Given this list of marker genes GNB2, GJA5, DNAJC19, DPH5, SVBP, ATP6V0A2, MYBPC3, WBP11, RPL3L, ALG12, NSD1, STAG2 (STAG2 cohesin complex component), PSMC1, GET3, TBX5, THOC6, PLD1, GJA8, MAP3K7, MYCN, DPH2, GATA6, PPP2CA, DSG1, RNU4ATAC, NUP188, here is a description of the gene set: Muscular ventricular septal defect species: Homo sapiens Human Gene Set: HP_MUSCULAR_VENTRICULAR_SEPTAL_DEFECT The trabecular septum is the largest part of the interventricular septum. It extends from the membranous septum to the apex and superiorly to the infundibular septum. A defect in the trabecular septum is called muscular VSD if the defect is completely rimmed by muscle.